The following is a description of a gene set: part of: Signaling by PDGFR in disease In addition to activating missense mutations and in-frame deletions, PDGFRA and PDGFRB are also subject to gene fusion events arising from chromosomal rearrangements. PDGFR fusions often consist of the cytosolic domain of the receptor tyrosine kinase fused to the N-terminal oligomerization domain of an intracellular protein, leading to ligand-independent dimerization and constitutive activation. To date there are about 35 identified PDGFR fusion partners, most of which form fusions with PDGFRB. The most common cytosolic fusion partners of PDGFRA is FIP1L1, an RNA processing factor. Fusion partners with PDGFRB are numerous but occurrence of these proteins is rare. Reactome Pathway: Signaling by cytosolic PDGFRA and PDGFRB fusion proteins species: Homo sapiens, and this is the list of marker genes: WDR48, STRN, FIP1L1